Given this list of marker genes Cep295 (centrosomal protein 295), Azin1, Rock2, Cep120, Poc1a (NCBI Gene Id 70235), Npm1, here is a description of the gene set: species: Mus musculus Mouse Gene Set: GOBP_POSITIVE_REGULATION_OF_CENTROSOME_DUPLICATION Any process that increases the frequency, rate or extent of centrosome duplication. Centrosome duplication is the replication of a centrosome, a structure comprised of a pair of centrioles and peri-centriolar material from which a microtubule spindle apparatus is organized.